The following is a description of a gene set: species: Homo sapiens from publication Chen Y, Wang X (PMID 31504780) Human Gene Set: MIR4771 Genes predicted to be targets of miRBase v22 microRNA hsa-miR-4771 in miRDB v6.0 with MirTarget v4 prediction scores > 80 (high confidence targets)., and this is the list of marker genes: GABRA1, BDNF, ELF5, ENOX2, EPS8, WDR48, CAPRIN1, PAPPA, CFAP91, ZC3H12C, ABCC5, TPBGL, NPLOC4, RAB8A, FAIM, KLK15, NIBAN1, PAIP2, CREBRF, ZNF79, CADM2, USP24, TNRC6B, SERF2, FILIP1L, INHBA, DNAJA4, MYBL1, IGFBP7, BCL6, EGR2, ZZZ3, C18orf63, AVIL, CCDC6, ZNF229, CAMSAP2, MAP4K4, CLASP2, NUFIP2, HECTD2, CYTIP, FAM222B, RBM44, NUP160, NOLC1, USP8, CLRN1 (clarin 1), VSNL1, USP12, NCBP2